The following is a description of a gene set: Human Gene Set: ZHONG_PFC_C5_BCL11B_CALB2_POS_INP from publication Zhong S, Zhang S, Fan X, Wu Q, Yan L, Dong J, Zhang H, Li L, Sun L, Pan N, Xu X, Tang F, Zhang J, Qiao J, Wang X (PMID 29539641) studied in species Homo sapiens, and this is the list of marker genes: ANK3, NAV1, KAT6B (NCBI Gene Id 23522), GAP43, LZTS1, CNTNAP2, RUNDC3A, NEUROD6, ATP2A2, NHLH1, BCL11B, YWHAG, CNIH2, CALB2, CELF4, THSD7A, XPR1, ST18, TP53I11, KIF21B, ZBTB18, TSPAN18